Given this list of marker genes BTN3A1, SP1, IRF7, CSNK1A1, MYPN, KRTAP9-8, MT1F, ADGRF2P, CARINH (NCBI Gene Id 441108), MGME1, SP110, CARD9, EFCAB7, SLC25A38, ELP3, HELZ2, SNHG1, LINC02901, SHISA5, CABCOCO1, ARSA, TMEM52B, SHFL (shiftless antiviral inhibitor of ribosomal frameshifting), IFI16, APOL2, TDRD7, TOB2, LCOR, IFI6, SENP6, USP48, B2M, TAPBP, IFI35, PIK3C3, RBM33, DDX5, PGAM1, LINC01686, PNPT1, RIGI, NR1I2, DDX60L, LRRFIP1, MOV10, PECR, PRCD, NT5C3A, SGPL1, LRCH2, PSMG2, DIS3L2, PARP12, HLA-A, C4orf33, TTC28, IRF9, SAMD9L, PHF11, DNAJC6, RASL12, CSMD1 (NCBI Gene Id 64478), OASL, IRX5, TAP2, ZNF766, DDX60, WWC3, FUT2, MIR646HG, PAIP2, PPM1K, LY6E, CREBRF, XRN1, SUPT7L, ZNF252P, SSBP2, HLA-B (major histocompatibility complex, class I, B), ISG15, AVL9, TBCK, IFIT5, SEPTIN4, IFITM2, GMPR, FMR1NB (FMR1 neighbor), BTN3A2, CDK5RAP1, BST2, ZNF544, GAGE1, MT1M, P2RY6, STAT2, TMEM161B-DT, RPRD1A, ERAP1, INTS8, OAS3, LINC01304, LAP3, MT2A, IFIT3, PSME1, MYT1, TRIM14, H2AC6, MYD88, ZNF24, PSME2 (proteasome activator subunit 2), TUG1, TRIM21, TMEM230, RBCK1, MPDZ, PATL2, PLSCR1, SAMD9, CLK1, USP18, TMEM245, DNAJA1, IFIT1, HERC6, LINC00587, STXBP5, GCM2, ZFP64, CTDSP2, EIF2AK2, PARP9, SUGT1, TRIM25, IFIT2, TMEM53, RSAD2, PPM1B, AZU1, PARP14, SHROOM3, ATM, ERP44, TLR3, LGALS3BP (galectin 3 binding protein), PCLO, POLR2M, AGTRAP, NLRC5, DNPEP, TMEM140, CMPK2, TRIM69, IFI27, LPL, STAT1, SLC25A21, HDHD2, ADAR, OR7C1, TMEM44-AS1, LIPJ, CHAT, ZNF540, MTTP, IFITM1, NPHP3-AS1, DPPA2, IFITM3, ADCY7 (adenylate cyclase 7), HLA-C, TBCA, MX1, NRBF2, MPLKIP, SCAMP1, VPS37A, LLPH, IFI30, RNF213, ADAMTS9, KEL, HLA-E, SLC9A9, SLC25A25-AS1, OAS1, TTC32, USP6 (ubiquitin specific peptidase 6), TLK2, OSBPL10, OPTN, DTX3L (deltex E3 ubiquitin ligase 3L), CMTR1, HLA-F, SP140L, MX2, GTPBP1, here is a description of the gene set: studied in species Homo sapiens Human Gene Set: GSE21546_ELK1_KO_VS_SAP1A_KO_AND_ELK1_KO_DP_THYMOCYTES_UP Removal of the transcription factor SAP1a member of the Ternary Complex Factor (TCF) group of transcription factors which in conjunction with Serum Response Factor (SRF) has been shown to have a profound effect on positive selection in the thymus. When another TCF Elk1 is knocked out in mice there is no effect on positive selection unless it is on a Sap1a KO background where the phenotype is very severe. We have stimulated isolated double positive T cells (DPs) with anti-CD3 to mimic positive selection and compared basal and stimulated transcription across the four genotypes to discover the downstream targets of Sap1a involved in positive selection. Genes up-regulated in untreated double positive thymocytes: ELK1 knockout versus ELK1 and ELK4 knockout. from publication Costello P, Nicolas R, Willoughby J, Wasylyk B, Nordheim A, Treisman R (PMID 20554967)